Given this list of marker genes Ifnb1, Tradd, Map3k7, Ccl20, Map3k14, Nfkb2, Nfkb1, Mapk1, Hsp90aa1, Map3k3, Ikbkg, Traf6, Ccl5, Ikbkb, Rela, Irak1, Tnf, Mapk8, Pdlim7, Traf1 (TNF receptor-associated factor 1), Chuk, here is a description of the gene set: studied in species Mus musculus EBV LMP1 signaling Mouse Gene Set: WP_EBV_LMP1_SIGNALING